The following is a description of a gene set: The process that gives rise to the cranial nerves. This process pertains to the initial formation of a structure from unspecified parts. The cranial nerves are composed of twelve pairs of nerves that emanate from the nervous tissue of the hindbrain. These nerves are sensory, motor, or mixed in nature, and provide the motor and general sensory innervation of the head, neck and viscera. They mediate vision, hearing, olfaction and taste and carry the parasympathetic innervation of the autonomic ganglia that control visceral functions. studied in species Mus musculus Mouse Gene Set: GOBP_CRANIAL_NERVE_FORMATION, and this is the list of marker genes: Neurog1, Phox2a, Plxna1, Tfap2a, Pax2, Hoxa1, Tifab, Atp8b1, Mafb, Plxna3